Given this list of marker genes SDC2, CX3CR1, GPC4, RAB5A, EGFR, FURIN, AGRN, GPC5, SDC3, CD14, SDC4, GPC3, LY96, GPC2, RAB5B, GPC6 (glypican 6), NCL, TLR4, SDC1, RAB5C, IGF1R, HSPG2, GPC1, here is a description of the gene set: Human Gene Set: REACTOME_RESPIRATORY_SYNCYTIAL_VIRUS_RSV_ATTACHMENT_AND_ENTRY Respiratory syncytial virus (RSV) attachment and entry species: Homo sapiens